Given this list of marker genes MKS1, SOX3, NUP107, SOX2, CHD7, WNT3, BMP15, SGMS2, COLEC11, NOTCH2, HHAT, SIX3, AFF4, METTL27, PAICS (NCBI Gene Id 647765), BMP4, MMP13, INPPL1, IARS2, PPP1R15B, APC, OFD1, FGFRL1, KANSL1, NOG, ADA, THPO, PDE4D, IFT43, AGA, VANGL1, WNT5A, TWIST1, MAP3K7 (NCBI Gene Id 6885), NSDHL, COL2A1, KDELR2, PEX7, WNT1, SERPINH1, CSPP1, FANCC, LRP4, OCRL, ALG12, CHRND, CDK10, MYH3, GDF3, SOST, TNNT3, SOX5 (NCBI Gene Id 6660), CHRNG, KIF22, STX1A, TBX4, GTF2I, B9D1, DYM, ZBTB20, TBXAS1, BRPF1, TMEM270, ARL13B, IFT74, TOGARAM1, STIL, PLOD1, PPIB, TMEM218, CTSA, GORAB, GNPAT, PRKG2, CRIPTO, CHST14, TRIP11, OTX2, LETM1, WASHC5, MID1 (NCBI Gene Id 8230), RINT1, MSH4, CUL7, TBX5, NPR2, MESD, DHX37, CDH23, B3GALT6, PTCH2, TMEM67, PDE6D, SMARCAL1, BCL11A, NADSYN1, RPS19, NODAL, TOMM7, SERPINF1, DKK1, TONSL, CCDC22, TCTN2, STAG2, SPIDR, SLC26A2, ARSK, COL9A1, COMP, FUZ, TCTN1, TBL2, PAX3, FSHR, COL1A1, WNT7A, TMEM237, P3H1, ZFX, LRRK1, NOTCH2NLC, MBTPS2, ACVR1, RMRP, HES7, UROS (uroporphyrinogen III synthase), KCNJ8, CDON, MADD, INPP5E, ELN, DACT1, BGN, POGZ, DDR2, DSE, CCND1, RAD21 (RAD21 cohesin complex component), PIEZO2, TMEM53, MRPS22, PYCR1, MESP2, TMCO1, JAG1, VPS35L, HNRNPR, SEC23A, ERI1, HTRA1, NKX3-2 (NK3 homeobox 2), SRP54, NAGLU, IHH, EXTL3, GDF11, FLNB, GRIP1, CTBP1, FBN1, GALNS, MAX, NRAS, ZIC2, MAN2B1, TGIF1 (TGFB induced factor homeobox 1), NOTCH3, GPC4, EBP, NEK9 (NCBI Gene Id 91754), PTH1R, GZF1, SLC39A13, WBP11, DLK1, POP1, TCTN3, RAB33B, P4HB, SUMF1, DHODH, COL11A1, SLC29A3, CLIP2, RAD51, ABCC6, RNU4ATAC, TAPT1 (NCBI Gene Id 202018), IDS, VANGL2, ACTB, KRAS, COL9A2, PLEKHM1, DDRGK1 (DDRGK domain containing 1), TNNI2, OTUD5, CAPN15, CEP120, DHCR7, EIF2AK3, CHD4, EIF4H, TENT5A, NSD2, NELFA, ARSB, HYLS1, IKBKG, PUF60 (poly(U) binding splicing factor 60), TBX15, ENPP1, GPC3, H3-3B, KIAA0753, NCF1, MIA3, SLC10A7, IDUA, FOXF1, CHRNA1, PAM16, PROP1, CCDC8, HOXD13, SH3PXD2B, SMS, LEMD3, PTDSS1, NTN1, GNPTAB, AXIN1, GPR101, BUD23, TRAPPC2, MRPS28, GTF2IRD1, SOX9, KIF7, RPS6KA3, ARSL, DCC, HSPG2, PHF6, FOXH1, IFITM5, FGFR1, AEBP1, NR3C1, SALL4, LYSET, TBC1D24, EFL1, MNX1, FKRP, FOXA2, ARMC9, GDF5, ATP6V1B2, NXN, ANTXR1, B3GAT3, PHEX, FZD2, NMNAT1, NR5A1, KMT2D, FANCI, SMOC1, TBX2, MBD5, USP8, WDR35, AIFM1, PMM2, EXOC6B, PCYT1A, HDAC6, OBSL1, B9D2, GPX4, COG1, ASH1L, AKT1, FRAS1, DNAL4, POR, NF1, CPLX1, GLB1, LONP1, SEMA3E, RUNX2, DISP1, TBX6, ZSWIM7, ACP5, ORC1, ROR2, DMP1, PSMC3IP, HRAS, FLNA, LIFR, SKI, SH2B1, COL11A2, ABCC9, PLCB3, CSGALNACT1, GJA1, CREB3L1, CHST3, CCL2, TCIRG1, UBE3B, CEP41, LHX4, FREM2, XYLT1, ASXL2, TNFRSF11A, CRTAP, FANCB, CHRM3, NFATC2, SC5D, ITCH, NALCN, DNAJC21, KYNU, VDR, LTBP1, GAS1, CDC45, SF3B2, FUCA1, COL9A3, HNRNPK, DYNC2I1, BNC1, CBY1, GDF6, VPS37D, TPM2, RTL1, BAZ1B, SPARC, PHLDB1, ARL3, POLR3A, SCARB2, GNS, CDH11, TP53, LIMK1 (LIM domain kinase 1), PRKAR1A, ESCO2, SLC25A24, CFAP410, MEOX1, RSPO2, ATRX, PTCH1, IPO8, LBR (lamin B receptor), HAAO, GLI2, POLR3H, GBA1, RPL13, KIAA0586, FLI1, PIGG, MMP2, COL1A2 (collagen type I alpha 2 chain), DYNC2H1, DLL1, B3GLCT, ZIC3, FKBP6, CHN1, GTF2IRD2, EIF5A, IFT80, DVL3, SMAD4, GUSB, CCN2, SF3B4, PIBF1, CEP104, LRP5, HNF1B, RIPPLY2, SBDS, CLCN7, FN1, CLCN3, FGFR3, XYLT2, FGFR2, WNT4, SUFU, ADAMTSL2, KDM6A, CYP27A1, AHI1, PLOD2, HIBCH, PLOD3, IL1RN, DVL1 (NCBI Gene Id 348497), LTBP3, SLC35D1, MPL (NCBI Gene Id 4352), NANS, SALL1 (spalt like transcription factor 1), MEG3 (NCBI Gene Id 55384), TRPV4, APC2, SHH (NCBI Gene Id 6469), LAMA5, IDH1, ALDH1A2, DNAJC30, ACAN, DLL3, ATP7A, DNA2, HGSNAT, CCN6, LFNG, TBXT (T-box transcription factor T), NEPRO, KATNIP, COL10A1, RBM8A, SEC24D, GLE1, MYO18B, SFRP4, CSF1R, MMP14, HSPA9, TAF1, FIG4, DPYSL5, COG4, ANKRD11, DYNC2I2, MAFB (NCBI Gene Id 9935), SGSH, MATN3, CCDC134 (coiled-coil domain containing 134), SLC35B2 (NCBI Gene Id 347734), BMP1, USP48, SON, RFC2, UFSP2, CBS, SIX6, KDM1A, FGF8, NEU1, HGD, RSPRY1, CPLANE1, NSD1, CANT1, GNPNAT1, POU1F1, BRAF, WNT3A, ALPL, FKBP10, HESX1, PAPSS2, AIP, FGD1, NEK1, BMPER, DPP9, RECQL4, GLI3, here is a description of the gene set: An abnormality of one or more of the vertebrae. Abnormal vertebral morphology Human Gene Set: HP_ABNORMAL_VERTEBRAL_MORPHOLOGY species: Homo sapiens